The following is a description of a gene set: Mouse Gene Set: NADLER_OBESITY_DN Genes down-regulated in adipose tissue from obese mouse strains compared to the lean ones. species: Mus musculus from publication Nadler ST, Stoehr JP, Schueler KL, Tanimoto G, Yandell BS, Attie AD (PMID 11027337) Obesity is strongly correlated with type 2 diabetes mellitus, a common disorder of glucose and lipid metabolism. Although adipocytes are critical in obesity, their role in diabetes has only recently been appreciated. We conducted studies by using DNA microarrays to identify differences in gene expression in adipose tissue from lean, obese, and obese-diabetic mice. The expression level of over 11,000 transcripts was analyzed, and 214 transcripts showed significant differences between lean and obese mice. Surprisingly, the expression of genes normally associated with adipocyte differentiation were down-regulated in obesity. Not all obese individuals will become diabetic; many remain normoglycemic despite profound obesity. Understanding the transition to obesity with concomitant diabetes will provide important clues to the pathogenesis of type 2 diabetes. Therefore, we examined the levels of gene expression in adipose tissue from five groups of obese mice with varying degrees of hyperglycemia, and we identified genes whose expression strongly correlated with diabetes severity. This group included many genes that are known to be involved in signal transduction and energy metabolism as well as genes not previously examined in the context of diabetes. Our data show that a decrease in expression of genes normally involved in adipogenesis is associated with obesity, and we further identify genes important for subsequent development of type 2 diabetes mellitus., and this is the list of marker genes: Gng11, Mccc1, Fmo1, Cyc1, Rbms2, Cyp2e1, Apoe, Tshr, Ppa1, Gbe1, Hbb-bs, Aldoa (NCBI Gene Id 11674), Ubb, Pygb, Scd1, Sdhb, Eef1a1, Uqcrc2, C2, Sod1, B2m, Asns, Gpd2, Rbp4, Dbi, Echs1, Pcx, Nnat, Hp, Atp5me, Agt, Cfd, Gnai1, Pck1, Ddt, Mylk, Thrsp, Bcat2, Gsta3, Ldhb, Adrb3, Uck1, Srebf1, Aldh2, Fabp4, Cdkn2c, Acly, Rasd1, Cox8a, Fdft1